The following is a description of a gene set: species: Mus musculus Mouse Gene Set: CUI_NK_CELL_BAFF_RESPONSE_UP from publication Cui A, Huang T, Li S, Ma A, Pérez JL, Sander C, Keskin DB, Wu CJ, Fraenkel E, Hacohen N (PMID 38057668) Genes positively differentially expressed in cell type: NK cell upon treatment with cytokine: BAFF in mouse lymph nodes in vivo. Cytokines mediate cell-cell communication in the immune system and represent important therapeutic targets. A myriad of studies have highlighted their central role in immune function, yet we lack a global view of the cellular responses of each immune cell type to each cytokine. To address this gap, the authors created the Immune Dictionary, a compendium of single-cell transcriptomic profiles of more than 17 immune cell types in response to each of 86 cytokines (>1,400 cytokine-cell type combinations) in mouse lymph nodes in vivo. A cytokine-centric view of the dictionary revealed that most cytokines induce highly cell-type-specific responses. For example, the inflammatory cytokine interleukin-1β induces distinct gene programmes in almost every cell type. A cell-type-centric view of the dictionary identified more than 66 cytokine-driven cellular polarization states across immune cell types, including previously uncharacterized states such as an interleukin-18-induced polyfunctional natural killer cell state., and this is the list of marker genes: S100a6, Pgk1, Cd74 (CD74 antigen (invariant polypeptide of major histocompatibility complex, class II antigen-associated)), Braf, Klrg1, Pfn1